Given this list of marker genes Sos1, Mapk3, Akt2, Pou3f1, Ntrk3, Pals1, Lamb2, Ilk, Itgb4, Adam22, Rela, Raf1, Ndrg1, Egr2, Pi4ka, Ski, Nab1, Sod1, Cntnap1, Sh3tc2, Nrg1, Nf1, Cdk5, Ppp3r1, Sirt2, Gpc1, Ntrk2, Dag1, Dhh, Adgrg6, Ncmap, Fa2h, Plec, Akt1, Mapk1, Col6a1, Map2k1, Med12, Lgi4, Pou3f2, Erbb3, Slc25a46, Map2k2, Dicer1, Hras, Arhgef10, Nab2, Pard3, Prx, Myoc, Grb2, Bag1, Pmp22, Lama2, Erbb2, here is a description of the gene set: species: Mus musculus The process in which a relatively unspecialized cell acquires the specialized features of a Schwann cell. Schwann cells are found in the peripheral nervous system, where they insulate neurons and axons, and regulate the environment in which neurons function. Mouse Gene Set: GOBP_SCHWANN_CELL_DIFFERENTIATION